The following is a description of a gene set: Human Gene Set: GOMF_C_X_C_CHEMOKINE_RECEPTOR_ACTIVITY studied in species Homo sapiens Combining with a C-X-C chemokine and transmitting the signal from one side of the membrane to the other to initiate a change in cell activity. A C-X-C chemokine has a single amino acid between the first two cysteines of the characteristic four cysteine motif., and this is the list of marker genes: CXCR4, ACKR3, CXCR3, CXCR6, CXCR1, CXCR2, CXCR5, GPR35